Given this list of marker genes TEAD4, LRGUK, ECHDC1, TRIM10, ATXN1, CCDC3, PSG8, ZNRF3, PTPRJ, CPNE8, ASB8, NUTF2, CLEC4D, TEAD1, SMIM10, FCGR1BP, CHST11, HCN1, CHERP, GHITM, LMLN, STK39, FGA, ZNF568, TENM3, MRPL20, ZFHX4, ETF1, RNF10, THBS4, PSEN1, ARK2C, MANBAL, FBN2, EGR2, COL1A1, HOXA1, ZBTB1 (NCBI Gene Id 22890), here is a description of the gene set: studied in species Homo sapiens Human Gene Set: MIR4507 from publication Chen Y, Wang X (PMID 31504780) Genes predicted to be targets of miRBase v22 microRNA hsa-miR-4507 in miRDB v6.0 with MirTarget v4 prediction scores > 80 (high confidence targets).